The following is a description of a gene set: Mouse Gene Set: MIR_6769B_3P Genes predicted to be targets of miRBase v22 microRNA mmu_miR_6769b_3p in miRDB v6.0 with MirTarget v4 prediction scores > 80 (high confidence targets). from publication Chen Y, Wang X (PMID 31504780) studied in species Mus musculus, and this is the list of marker genes: Slc2a1, Hmbs, Asic2, Dtwd2, Tafa1, Thy1, Pnpla8, Calhm5, Fbxl16, Trib2, Ropn1, Kcne3, Cdkn1b, Mctp1, Ppp4r3c2, Pdcd6ip, Ppp6r1, Bckdhb, Ppp4r2, Nsd2, Ermap, Arpc1a, Nim1k, Zfp850, Cetn1, Eef1b2, Napg, Pigk, Slc5a8, Dlc1, Mettl9, Nedd9, Elovl1, Myl12a, Skida1, Dennd1b, Prr11, Fam135a, Naa50, Garre1, Tfrc, Wnt5a, Slc31a1, Cyp4v3, Zfp106, Mtcp1, Ddx19b, Zfp217, Esrrg, Tmem167, Rd3, Slc36a4, Zfp449 (NCBI Gene Id 78619), Man2a1, Gtf2h5, Ccdc85a, Cdr1, C3ar1, Kdm7a, Slc15a2, Epdr1, Fbxo11, Clec4b2, Sgk1 (NCBI Gene Id 20393), Camk1, Lekr1, Fastkd2, Tubgcp4, Itprid2, Coro1b, Gk5, Scn1a, Camta1, Lamp3, Pnp, Epm2aip1